The following is a description of a gene set: studied in species Homo sapiens Genes up-regulated in monocyte-derived dendritic cells: untreated versus LPS and LPS like antigen from O. planktothrix (3h). from publication Macagno A, Molteni M, Rinaldi A, Bertoni F, Lanzavecchia A, Rossetti C, Sallusto F (PMID 16717116) Human Gene Set: GSE4748_CTRL_VS_LPS_AND_CYANOBACTERIUM_LPSLIKE_STIM_DC_3H_UP A cyanobacterial LPS antagonist prevents endotoxin shock and blocks sustained TLR4 stimulation required for cytokine expression. We report the identification and biologic characterization of an LPS-like molecule extracted from the cyanobacterium Oscillatoria Planktothrix FP1 (CyP)., and this is the list of marker genes: PHYHD1, NPC2, KLF2, CLK1, TGIF1, NFYB, ZNF841, RGS5, IL13RA2, PDE4B, TNS2, CLBA1, DMTF1, BTN1A1, UCHL1, DDX50, NUDT9, ILF3, SLC22A23, ANXA3, CCDC47, KRI1, ISLR, ESD, SRCAP, RPAP3, MPG, AGAP1 (ArfGAP with GTPase domain, ankyrin repeat and PH domain 1), SGK1, TMEM176A, LMAN1, CXCL6, DPYSL3, GPR153, AREG, NEAT1, GCH1, FBXW2, AKAP12, PRXL2A, SAA1, SAT1, TUT7, WASF2, AHI1, POLDIP3, TRIB2, MEMO1, HS6ST2 (heparan sulfate 6-O-sulfotransferase 2), GSTO1, IL33, SMS, WDR36, EREG, LPIN2, IMPACT, NOP14, ANXA1, LAMA4, AQP1, ECHDC3, ZFAND1, SLC44A2, CLCN5, RGCC, GHR (NCBI Gene Id 2690), GNG12, ITGB3BP, CTNNA1, TMTC4, BCL2L11, CTDSP2, IFNAR2, MMP3, RGS16, PRDX4, ACTG2, FIP1L1, RGS4, AMPD3 (NCBI Gene Id 272), FEM1B, SLC25A28, EWSR1, CAB39, TSLP, GFPT2, ALDH3A2, CDKN2C, HSCB (HscB mitochondrial iron-sulfur cluster cochaperone), EP400, ANTXR2, RRP1, ANKRD1, TCIM, DAB2, STRN, OSER1, PPP1R3C, LMNB1, CD53, RBM10, ATXN7L3B, PLPP2, ACKR3, UBE2D1, TGFBI, TSPAN5, CCN2, TBL1X, ETV1, PML, WDR20, RAI14, CXCL12, BMP6, PIK3R4, MORF4L1, PRKD3, PEAK1, C1QTNF1, DNAJC21, LCN2, PTGR3, SEC23B, IL1RAP, CDC42EP1, DHRS3, PLEC, MAN2A1, PRPF6 (pre-mRNA processing factor 6), SLIT2, GOSR2, TRPT1, MATN2, LRIG1, SH3D19, AAR2, HECTD1, RPS8, GADD45A, SQOR, AP3B1, RASSF5, FNDC3A, RBFOX1, RASSF8, BLTP2, TDP2, CCND1, PAICS, DNAJB4, SOX9, KDM3B, SPCS2, GREM1, TXNDC12, GABARAP, C1orf174, ADGRA2, CES1, TES, PLEKHA2, MLXIP, CTPS1, JAM2, ERRFI1, SUPT16H, PTPN22, APOBEC1, PLXDC2, FAM32A, NTN1 (NCBI Gene Id 9423), PBX1, IL1R1, ENPP2, ITM2C, TGFB1I1, PCOLCE2, IL1RL1, MITF, TMEM176B, RIN2, FAM20C, BDNF, TAGLN, ATF1, RAB3IP, FARP1, MMP10, LAMP2, CCK, SPTSSA, TM4SF1, RAP2A, POLR2M, EPHB3, TSTD2, OXR1, CTSV, GTF2IRD1